Given this list of marker genes F12, F2, KLKB1, here is a description of the gene set: Reactome Pathway: Defective factor XII causes hereditary angioedema part of: Defects of contact activation system and kallikrein-kinin system  studied in species Homo sapiens Hereditary angioedema (HAE) is a rare life-threatening inherited edema disorder that is characterized by recurrent episodes of localized edema of the skin or of the mucosa of the gastrointestinal tract or upper airway. The edema formation in patients with HAE is primarily caused by a transient increased bradykinin release from high molecular weight kininogen (HK) due to uncontrolled activation of the coagulation factor XII (FXII)-dependent kallikrein kinin system (KKS) (Bossi F et al. 2009; Kaplan AP 2010; Suffritti C et al. 2014: Zuraw BL & Christiansen SC 2016). Angioedema initiated by bradykinin is usually associated with SERPING1 (C1-INH) deficiency. SERPING1 is the major regulator of the contact system. More rarely, HAE occurs in individuals with normal SERPING1 activity, and has been linked to mutations in other proteins, including FXII, plasminogen, and angiopoietin (Magerl M et al. 2017; Zuraw BL 2018; Ivanov I et al. 2019). Substitution of threonine 328 by either a lysine or an arginine residue (T328K or T328R) in the FXII proline-rich region has been identified in several families with HAE and normal SERPING1. FXII T328K or T328R variants change protein glycosylation and introduce a new site that is sensitive to enzymatic cleavage by fibrinolytic and coagulation proteases such as plasmin, thrombin, or FXIa (de Maat S et al. 2016; Ivanov I et al. 2019). The intrinsic capacity of the truncated form of FXII (329-615) (also known as δFXII) to convert prekallikrein to kallikrein is greater than that of FXII leading to more kallikrein generated early during reciprocal activation (Ivanov I et al. 2019). Second, FXII (329-615) is a better kallikrein substrate than is FXII. The accelerated kallikrein/FXII activation with truncated FXII (329-615) appears to overwhelm the regulatory function of SERPING1 at normal plasma levels leading to uncontrolled bradykinin formation (de Maat S et al. 2016; Ivanov I et al. 2019). Binding of the proinflammatory peptide hormone bradykinin to the bradykinin B2 receptor (B2R) activates various proinflammatory signaling pathways that increase vascular permeability and fluid efflux. An excessive formation of bradykinin due to uncontrolled activation of FXII-dependent KKS causes increased vascular permeability at the level of the postcapillary venule and results in HAE (Zuraw BL & Christiansen SC 2016; de Maat S et al. 2016; Ivanov I et al. 2019).